The following is a description of a gene set: This event has been computationally inferred from an event that has been demonstrated in another species.<p>The inference is based on the homology mapping from PANTHER. Briefly, reactions for which all involved PhysicalEntities (in input, output and catalyst) have a mapped orthologue/paralogue (for complexes at least 75% of components must have a mapping) are inferred to the other species. electronically inferred by orthology from the curated human pathway Reactome Pathway: Signaling by GPCR part of: Signal Transduction studied in species Mus musculus, and this is the list of marker genes: Opn5, Pth2, Rgs2, Edn2, Glp1r (NCBI Gene Id 14652), Ffar1, Crhr1, Ccl19, Adcy7, Daglb, Hcar2, Sstr3, Gip, Brs3, Tas2r131, Drd4 (NCBI Gene Id 13491), Gipr, Arhgef10l, Kel, Shc1 (NCBI Gene Id 20416), Prkacb, Sst, Grk5, Hcar1, Pomc, Taar8c, Prkcg, Casr, Ptgir, Adra2b, Gng3, Npff, Camkk2 (NCBI Gene Id 207565), Pyy, Uts2, Htr4, Pnoc, S1pr3, Tas2r135 (taste receptor, type 2, member 135), Cxcl9, Vipr2, Trhr, Arhgef37, Mc3r, Pdpk1, Mapk3, Pik3r5, Edn3, Gna13, Opn1sw, Gcg, Gnrhr, Taar1, Kiss1, Tas2r138, Tas2r107, Oprl1, Tas2r137, Prex1, Dagla, Gprc6a, Npw, Gpr176 (G protein-coupled receptor 176), Uts2b, Xcr1, P2ry4, Fpr-rs7, Gnb3, Npy1r, P2ry1, Gpr15, Tas1r3 (NCBI Gene Id 83771), C3ar1, Htr6, C5ar2 (NCBI Gene Id 319430), Trpc7, Itga5, Gpr132, Ramp3, Crhr2, Tshr, Hrh3 (NCBI Gene Id 99296), Ccr10, Ghrhr, Mmp3, Rgs7, Nmu, Sstr1, Aplnr, Tacr2, Rgs18, Chrm2 (NCBI Gene Id 243764), Nmb, Gng7, Gnat3, Drd3, Ppp2r1b, Cxcl2, Cxcl16, Prokr2, Cckar, Dgkh, Hcrtr2, Tacr1, Gpha2, Eef1ece2, Prkar1b, P2ry10, Cckbr, Rln3, Ackr4, Ednrb, Nmur1, Tas2r139, Mtnr1a, Gngt2, Sucnr1, Lpar2, Gpr143, Pth2r, Psap, Penk, Pde1b, Fgd1, Adm2, Rgs9, Oprd1, Bdkrb1, Gpr35, Plppr1, Qrfprl, Prkca, Adcy8, Cxcl12, Prkar2b, Gpr150, Chrm1, Fpr-rs4, Sstr4, Egfr, Rhob, Adrb3, Prok1, Qrfp, Avpr2, Tas2r120, Mchr1, Taar3 (trace amine-associated receptor 3), Mc2r, Avpr1a, Ccl7, Nms, Cck, Oprm1, Pde7b, Cdc42, Adm, Cxcr6, Grk3, Ptger2, F2rl1, Adcyap1, Ccl20 (NCBI Gene Id 20297), Ccl12, Tas2r144, Hcrtr1, Plppr3, Fpr1, Pf4, Gpr83, Galr1, Hrh1, Gpr4, Trh, Cxcr4, Ccr6, Tas2r118, Gpr17 (G protein-coupled receptor 17), Cxcr5, Avpr1b, Cort, Tas1r2, Kng2, Tas2r108, Gpr27, Vav1, Ucn2, Kiss1r, Taar8b, Arhgef10, Gal, Npy2r, Fpr-rs3, Galr3, Chrm3, Gng8, Gphb5, Ccl11, Pde10a, Npsr1, Tas2r136, Gna14, Gast, Pik3r2, Tbxa2r, Hrh4, C3, Hebp1, Pth1r, Uts2r, Opn3, Ccr8, Pcp2, Arrb2, Gpsm3, Prlhr, Ccl5, Prkch (NCBI Gene Id 18755), Hras, Cx3cr1, Ucn3, Ghsr, P2ry2, Ptgdr2, Gnaz (NCBI Gene Id 14687), Arhgef38, Ptgdr, Ffar3, Adcy5, Itsn1, Glp2r, Ackr2, Cysltr2 (NCBI Gene Id 70086), Rgs14 (regulator of G-protein signaling 14), Hc, Gnb5, F2rl3, Gngt1, Cxcl10, Htr7, Ccl21a, Vip, C5ar1, Calm1, Ucn, Grp, Dgki, Adra1a, Plppr5, Chrm4, Ccr3, Cxcr3, Ppy, Pde2a, Htr1f, Ppp1ca, Opn4, Gpr84, Gnai1, Taar9, Ccr7, Gabbr1, Crhbp, Adra2c, Drd5, Sct, Rgr (retinal G protein coupled receptor), Sstr2, Arhgef17, Cxcl1, Prokr1, Gnat1, Rrh, Rgs1, Gpr65, Ccr1, Vipr1, Nmur2 (NCBI Gene Id 216749), Gpbar1, Lpar5, Ngef, Galr2, Gnb2 (guanine nucleotide binding protein (G protein), beta 2), Ccl6, Ghrh, P2ry13 (purinergic receptor P2Y, G-protein coupled 13), Oxtr, Prkaca, Fshb, Ffar2, Cd55, Arhgef3, Arhgef15, Ccr4, Edn1, Mc1r, Htr2c, Cnr1, Ltb4r1, Sctr, Fgd2, Fpr-rs6, Plcb3, Tac2, Ccl9, Cxcr1, Gcgr, Tas2r119, Gpr20, S1pr5, Gper1, Ccl17, Adgre5, Gng10, Grk6, Tas2r126, Ntsr1, Taar5, Rgs6, Gng11, Mapk7, Ccl3, Arhgef1, Sos2, Cxcl3, Ptger4, S1pr4, Adora2a, Rho, Arhgef12, Adrb1 (NCBI Gene Id 11554), Drd2, Lpar6, Camkk1, Gng4, Trpc6, Ccl28, F2, Cmklr1, Adra2a, Gpsm2, Dgkb, Rxfp4, Rxfp3, Gna12, Pde1c, Mc4r, Gpr68, Rgs4 (regulator of G-protein signaling 4), Hcrt, Insl5, Rxfp2, Ece1, Ppp2r5d, Tas2r121, Ccl4, Htr1a, Lpar3, Pde8a, Ptger1, Npb, Bdkrb2, Tas2r130, Ccl21e, Fshr, Cxcr2, Arhgef33, Arhgef39, Gng5, Cga, Oxgr1, Agtr2, Rgs16, Cdk5, Lpar4, Grm4, Grb2, Ccl21f (NCBI Gene Id 100504346), Tas2r105, Htr5a, Oxt (oxytocin), Avp, Nts, Dgka, Htr1b, Cnr2, Grpr, Rgs8, Npffr1, Iapp, Arhgef7, Prok2, Gpr183, Mc5r, Hrh2, Npy4r, Rgs13, Cysltr1, Ntsr2